Given this list of marker genes Tgfb2, Ednra, Hes1, Adgrf4, Smarca4, Bmpr1a, Nog, Folr1, Adgrf5, Bmp4, Edn1, Megf8, Bmpr2, here is a description of the gene set: The process in which the anatomical structures of a pharyngeal arch artery is generated and organized. The pharyngeal arch arteries are a series of six paired embryological vascular structures, the development of which give rise to several major arteries, such as the stapedial artery, the middle meningeal artery, the internal carotid artery and the pulmonary artery. species: Mus musculus Mouse Gene Set: GOBP_PHARYNGEAL_ARCH_ARTERY_MORPHOGENESIS